Given this list of marker genes H1-2, CYP4A22, GPI, AURKA, CES1, CYP2B6, CRY1, ORM1 (orosomucoid 1), TUBB2A, ALAD, BMAL1, here is a description of the gene set: from publication Wiemann SU, Satyanarayana A, Buer J, Kamino K, Manns MP, Rudolph KL (PMID 15608677) Genes up-regulated by telomere shortening due to the knockout of TERC in the presence of chronic liver damage. Telomere shortening limits the regenerative capacity of cells during aging and chronic disease but at the same time inhibits tumor progression, and it has yet to be determined which of these mechanisms is dominantly affecting organismal survival. Here we show that telomere shortening in telomerase knockout (mTERC-/-) mice in combination with chronic liver damage significantly reduced organismal survival even though telomere shortening strongly inhibited liver tumor formation. Decreased survival induced by telomere shortening correlated with an imbalance between liver cell proliferation and liver cell apoptosis. Specific changes in gene expression were associated with telomere shortening and chronic liver damage and these gene expression changes were partially reversed by adenovirus mediated telomerase gene delivery. This study gives experimental evidence that the negative impact of telomere shortening on organ homeostasis and organismal survival can surpass the beneficial effects of telomere shortening on suppression of tumor growth in the setting of chronic organ damage. species: Mus musculus Human Gene Set: WIEMANN_TELOMERE_SHORTENING_AND_CHRONIC_LIVER_DAMAGE_UP